The following is a description of a gene set: studied in species Mus musculus Signaling by Type 1 Insulin-like Growth Factor 1 Receptor (IGF1R) Mouse Gene Set: REACTOME_SIGNALING_BY_TYPE_1_INSULIN_LIKE_GROWTH_FACTOR_1_RECEPTOR_IGF1R, and this is the list of marker genes: Fgf2, Sos1, Pik3r1, Fgf18, Igf1r, Fgf20, Them4, Irs4, Fgfr4, Grb2, Akt2 (thymoma viral proto-oncogene 2), Fgf17, Fgf5, Fgf9, Fgf23, Pik3cb, Shc1 (src homology 2 domain-containing transforming protein C1), Irs2, Pik3ca, Trib3, Kl, Cilp (cartilage intermediate layer protein, nucleotide pyrophosphohydrolase), Klb, Frs2, Flt3l, Ptpn11, Fgfr1, Fgf7, Pik3c3, Igf1, Fgf3, Fgf10, Pik3r2, Fgf8, Pik3r4, Igf2, Fgf22, Gab1, Fgf1, Fgf6, Fgf15, Pdpk1, Fgf16, Fgf4, Fgfr3, Tlr9